Given this list of marker genes NREP, SPIB (NCBI Gene Id 6689), SPMIP6, KLF9, FBXW7, PLAG1, LGSN, RPRD2, TSC22D3, DLX5 (NCBI Gene Id 80275), SUMO1, IL4, RORA, CHN1, POGZ (NCBI Gene Id 23126), CRIM1, AKTIP, SECISBP2L, OXNAD1 (oxidoreductase NAD binding domain containing 1), FOXO3, CCDC47, SERTAD4, HOXC6, CDKL5, MECP2, PHC3, RBFOX1, LINC00114, SH2B3, CXCL6, RHOBTB2, ANKRD40, PCSK2, NEUROD6, HRH3, ZDHHC5, GPR85, ELMOD1, PNMA1, PDP1, CSNK1E, GTPBP2, MPP2, FAIM2, ING1, PRICKLE1, FOXA2, ATAD2, CADM1, TSC22D1, CDH10 (cadherin 10), HNRNPA3, NPTX1, TOP1, DCAF6, NAA60 (NCBI Gene Id 79903), CLCN5, ACSL4, ECM2, SPRED1, ADNP, CLASP1, TAGLN3, RPS6KA3, CALM1, UBE2E2, PKNOX2, LOX, MIOX, CLIC4, H2AC25, ZNF654, NFIL3, EIF4A1, NUFIP2, RMDN3, MIDEAS, PLCB1, CDYL, ERF, PDXP, BHLHE40, FGF21, IFNG, DNAJA2, GBX2, CTDSP1, PFN2, SYT11, STK35, INPP4A (inositol polyphosphate-4-phosphatase type I A), S100PBP (S100P binding protein), COL15A1, WNT3A, MEIS2, H2BC26, ENSA, HOXB6, PDAP1, OSBPL6, SPRR1B, IL27, CTSC, SLC24A2, PTHLH, XK, TOB1, USP2, USP9X, NDST3, NYX, PDGFRL, PRKG1, CACNA2D3, ARRDC3, CACNG2, TNFSF15, ZNF711, LGALSL, EML4, ADGRB3, ELAVL4, PRKAA2, TFEB, JPH3, ANO1, XPO7, NAPEPLD, ALDH1A1 (NCBI Gene Id 96075), TMEM154, NTRK1, CD40LG, ZFYVE9, ADRB2, KRTAP19-5, ETV4, RGR, TNFSF13, ADGRG4, MEOX2, OTX2, PELI2, TBX6, PRKAG1, LARP4, PDE4D, AGO3, TCEAL7, FOXP1, OCRL, DUSP14, MAP2K6, DMD, TAC1, NPVF, HERPUD1, NEUROD1, PIP5K1A, DENND4A, RASGEF1A (RasGEF domain family member 1A), IP6K2 (NCBI Gene Id 51447), ZBTB18, YWHAG, SPRY4, HS6ST2, EGFR, MYL6B, ARID1B (NCBI Gene Id 645070), HOXA4, BSN, DPH3, OTP, LEMD2, FBXO3, CASK, PREX2, EEF2, ABHD8 (abhydrolase domain containing 8, NCBI Gene Id 79575), SULF1, CALCRL, CHD2, BEST3, CASS4, DDIT3, MRC2, HIVEP3, GRHL2, RCC2, TNNC2, RASL10B, MACO1, FCHSD2, PALS2 (protein associated with LIN7 2, MAGUK p55 family member), HSPA4L, ATXN1, NR1D1, PPL, SLC46A3, VNN3P, NR2F2, MKNK2, TXLNG, CREB5, KIF2B, HNRNPH1, PDZD8, EPN2, ABHD11, RBFOX2, ZDHHC2, CELF2, BAMBI, CDKN2C, KLHL7, LONRF3, ZDHHC14, FBXW4, TNS2, MBNL2, NFKBIZ, SMARCAD1, TRIM8, TTC39B, TREX1, BCL6, MAP4, NTN5 (netrin 5), POU4F1, FNBP1, AP1S2, ZNF687, CDK8, F5, IRF2BP1, AQP9, PCBP2, SLIT3, SEMA6D, ANGPTL1, LRRTM4, PIK3R1, ARHGAP44, FOXA1, CDC42, ALB, EPB41, DLX1, KRT23, SREBF2, ZBTB21, CNTF, BUD31, DDX5, SETD7, HOXC4, NCKAP5 (NCBI Gene Id 401013), ROBO1, UBE2E4P (NCBI Gene Id 286480), SHMT2, here is a description of the gene set: studied in species Homo sapiens Genes having at least one occurrence of the motif GTTACRYAAT in the regions spanning 4 kb centered on their transcription starting sites. This matches the HLF transcription factor binding site V$HLF_01 (v7.4 TRANSFAC). Human Gene Set: HLF_01